Given this list of marker genes CFAP43, DNHD1, AKAP3, SSX1, FSIP2, QRICH2 (glutamine rich 2), BRWD1, CFAP91, DZIP1, CCDC34, DNAH2, DNAH8, CFAP44, DNAH17, TTC21A, SPEF2, CFAP251, CCDC146 (coiled-coil domain containing 146), CFAP58, DRC1, CFAP65, DNAH10, CFAP47, STK33, WDR19, CFAP61 (cilia and flagella associated protein 61), AK7, TTC29, LRRC23, ARMC2, DNAH1, here is a description of the gene set: Sperm cells lacking flagella. Absent sperm flagella Human Gene Set: HP_ABSENT_SPERM_FLAGELLA studied in species Homo sapiens